Given this list of marker genes ERAP1, SLCO2A1, FOCAD (focadhesin), DLL4, PHYH, SKIC2, CTC1, IRF4, STAT4, HGSNAT, TMEM67, COG1, COX10, TNFRSF13C, MMEL1, PTPN2, PNP, LPL, YME1L1, IRF1, CTSA, HEXB, ARVCF, WDR35, RNF31, FGA, YARS1, VPS33B, AP3D1 (NCBI Gene Id 8943), NOP10, RTL1, BACH2, TNFRSF1B, GNPTAB, TNFSF15, ABL1, HPGD, NLRC4, IFNG, THPO, MECOM, BTNL2, DOCK11, SPTA1, BCL11A, SEMA4D, PRF1, SEC24C, TPP2, ZFYVE19, UNC13D, BSCL2, ICOS, ATM (ATM serine/threonine kinase), TET2, SAMHD1, OTC, CASP10, CLDN1 (claudin 1), ASAH1, CASR, STEAP3, IL6ST, B4GALT1, BPGM, GATA1, IDS, KCNN3, C4A, FCHO1, TNFRSF13B, RNASEH2C, SCYL1, PRKCD, TFE3, WRAP53, HBG1, SP110, HBB, PIEZO1, IKBKG, GNS, RBM8A, FYB1, CDKN2A, BCL2, PNPLA2, ZNF699, ADA2, ABCA12, DGUOK, CYBC1, GYPC, KLF1, HLA-B, NGLY1, ABCB11, TNPO3, IRF8, CYP27B1, IKZF3, MYO5B, TNFRSF9, NFKB1, ARPC5, VPS11, DKC1, NCF1, RHCE, PSMB4, CYBA, TALDO1, SLC25A13, HLA-DRB1, GBE1, RNU7-1, PALB2, UBAC2, GALK1, NHP2, HBA1, MIF, COG6, SGSH, IL12RB1, PIK3CA, SYK, PSMG2, NCKAP1L, OCLN (NCBI Gene Id 4950), KDM6A, TINF2, CALR, RNASEH2A, XIAP, TCIRG1, JAK3, NAE1, FASLG, IDUA, MCTS1, HBA2, BCL6, JMJD1C, IL10, LMNA, BCR, NOTCH2, USB1, GLIS3, IL12A-AS1, NPC2, POT1, FAH, MVK, TCF3, LIG4, VPS13A, ARSB, TYMS, POU2AF1, ADAR, STAT3 (NCBI Gene Id 6774), ZAP70, MEG3, MMUT, MYD88, CCDC47, PDCD1, SLC17A5, COX4I2, PTPN22, APOE, ALAS2, PDGFRA, LSM11, IL12A, TCF4, CD81, PIK3CG, CTNS, SLC2A1, PTPRC, CARD11, GLB1 (galactosidase beta 1), SLC19A1, PTEN, CTLA4, KRAS, ADA, PALLD, SAA1, AP3B1, IL7R, MED12, COMT, CD3E, KIF3B, GLRX5, RFX5, ADAMTS3, TNFRSF1A, IL2RA, BRCA1, VPS45, IFT56, ALG1, GPC4, IRF2BP2, CD19, RFXAP, SLC7A7, NOD2, SNX10, LBR, KLRC4, TRAC, RREB1 (ras responsive element binding protein 1), EPB42, LCAT, CA2, MAGT1, GP1BB, G6PD, UBR1, FCGR2A, IL2RG, PEX7, PIK3CD, OSTM1, SRSF2, ATP6V1B2, CDAN1, ITK, NBEAL2, USP53, NOTCH1, ALPK1, SNX14, CCND1, CLCN7, PSAP, INPPL1, PLEKHM1 (pleckstrin homology and RUN domain containing M1), ERCC8, HSD3B7, MICU1, EPOR, NDUFS4, MPV17, BRAF, PHKG2, ANKRD55, FAT4, KCNN4, AKR1D1, DNASE1L3, SEC23B, CD28, MOGS, TERC, RORC, KMT2D (NCBI Gene Id 8085), PKHD1, CBL, VPS33A, DHCR24, STIM1, SKIC3, FAS, SAMD9L, F5, RHD, HK1, AGA, APOC2, TRNT1, NLRP1, FARSA (NCBI Gene Id 2193), TPI1, RNASEH2B (NCBI Gene Id 79621), RUNX1, RINT1, HAVCR2, RNU4ATAC, ERCC6, TGFB1, CLPB, NHLRC2, KPTN, SHARPIN, XK, CCR1, LAT, CYP7B1, TNFSF12, FMO3, GAA, NRAS, TRPV6, MKS1, CSF3R, IFNGR1, JAK2, SPIN4, RBCK1, PPARG, NPM1, SH2B3, HIRA, COG4, ERBB3, MST1, TERT, ABCA1 (NCBI Gene Id 8371), ALMS1, STAT1, TNFRSF4, GNB2, CASK, SUMF1, SLC29A3, GIMAP5, ATP7B, PEX13, SOX10, PKLR, PARN, AFF4, GATA2, GBA1, ATRX, RTEL1, ZNFX1, STX11, INSR, BMP6, TREX1, BMP2, SCARB2, CC2D2A, CD3D, DPM1, TULP3, MCM4, UMPS, GPIHBP1, CCBE1, FGFR2, IFT140, ABCB4, GNE, TLR4, LACC1, INPP5E, RHAG, SMPD1, IRF5, RPGRIP1L, ATP6AP1, RAB27A, PEPD, PSMB9, SPTB, FOXP3, SLC30A10, NLRP3, MAP2K1, TP53, PSMB8, ABCD3, LRBA, HSD17B4, DDRGK1, HFE, LPIN2, IL2RB, IL1RN, DLK1, CSPP1, POLD3, MAN2B1, IL23R, LYN, RAG2, JAK1, CFAP410, CFTR, UROS, NEU1, RAC2, SH2D1A, RABL3, NCF2, NLRP12, PSMB10, TLR8, CCDC115, CASP8, PIGM, ALDOA, CYP2R1, RIPK1 (NCBI Gene Id 8737, receptor interacting serine/threonine kinase 1), STXBP2, PHKA2, RASGRP1, DNASE2, DYNC2LI1, SLC37A4, SLC4A1, ASXL1, TBXAS1, CHD7, TNFRSF11A, COG7, CAVIN1, DZIP1L, NFKBIA, IFT172, CPOX, MPIG6B, NFKB2, ATP8B1, GUSB, HMBS, CTSK, GPD1, KCNH1, GEMIN4, CDIN1, CD247, TBX1, CD27 (NCBI Gene Id 939), CD40LG, PHEX (NCBI Gene Id 5251), GALE, IARS1, SOCS1, SERPINA1, ITCH, RAG1, PIGA, PIBF1, CAV1, HBG2, LYST, MS4A1, AKT1, RMRP, SMAD4, ABCG5, LIPA, DHCR7, NPHP3, COG5 (NCBI Gene Id 10466), IL6, ALG9, IFIH1, ANK1, GPR35, KIT, NCF4, FERMT3, PEX2, SLC39A4, DCDC2 (doublecortin domain containing 2), MEFV, TNFSF11, NPC1, PIK3C2A, PIK3R1, SF3B1, UFD1, HCK, WDR1, OAS1, UROD, GPI (glucose-6-phosphate isomerase), ABCG8, FUCA1, MPL, CR2, BRCA2, AGPAT2, HJV, PHKB, DCLRE1C, SPIB, HAMP, GP1BA, EPB41, CD70, GPC3, PSTPIP1, CYBB, NAGLU, GCLC (NCBI Gene Id 2729), G6PC3, BTD, here is a description of the gene set: Abnormal increased size of the spleen. Splenomegaly Human Gene Set: HP_SPLENOMEGALY studied in species Homo sapiens